Given this list of marker genes ADRA2B, SLC22A3, SLC22A1, CRH, CARTPT (CART prepropeptide), VIP, ADRA2C, GABBR1, SLC22A2, SLC29A4, ADRA2A, here is a description of the gene set: Human Gene Set: GOBP_EPINEPHRINE_TRANSPORT species: Homo sapiens The directed movement of epinephrine into, out of or within a cell, or between cells, by means of some agent such as a transporter or pore.